The following is a description of a gene set: from publication Cui A, Huang T, Li S, Ma A, Pérez JL, Sander C, Keskin DB, Wu CJ, Fraenkel E, Hacohen N (PMID 38057668) Genes positively differentially expressed in cell type: Macrophage upon treatment with cytokine: IFN-γ in mouse lymph nodes in vivo. Cytokines mediate cell-cell communication in the immune system and represent important therapeutic targets. A myriad of studies have highlighted their central role in immune function, yet we lack a global view of the cellular responses of each immune cell type to each cytokine. To address this gap, the authors created the Immune Dictionary, a compendium of single-cell transcriptomic profiles of more than 17 immune cell types in response to each of 86 cytokines (>1,400 cytokine-cell type combinations) in mouse lymph nodes in vivo. A cytokine-centric view of the dictionary revealed that most cytokines induce highly cell-type-specific responses. For example, the inflammatory cytokine interleukin-1β induces distinct gene programmes in almost every cell type. A cell-type-centric view of the dictionary identified more than 66 cytokine-driven cellular polarization states across immune cell types, including previously uncharacterized states such as an interleukin-18-induced polyfunctional natural killer cell state. Mouse Gene Set: CUI_MACROPHAGE_IFNG_RESPONSE_UP species: Mus musculus, and this is the list of marker genes: Oasl2, Abhd17b, Plaat3, Arf6, Socs1, Gatm, Ube2l6, Socs2, Eif1a, Glipr2 (NCBI Gene Id 97132, GLI pathogenesis-related 2), Fcgr1, Prkx, Ccl8, Btg1, Pphln1, Parp12, Usp18, Themis2, Stat3, Rmdn3, Slamf8, Crem (cAMP responsive element modulator), Sell, Actg1, Vdac2 (voltage-dependent anion channel 2), Sumo2, Gnaq, Cycs, Basp1, Psme2, Vwf, Ifitm1 (interferon induced transmembrane protein 1), Irf7, Rtp4, Flot1, Irgm2, H3f3b, Ccl7 (NCBI Gene Id 20306), Mndal, Spi1, Gpt2, Parp9, Eef1e1, Casp8, Ilrun, Ifit2 (interferon-induced protein with tetratricopeptide repeats 2, NCBI Gene Id 15958), Irgm1, Ube2d3, Iigp1, Etf1, Psmb9, Pmpcb, Nampt, Hprt1, H2-T23, Sp110, Gbp4 (NCBI Gene Id 17472), Jund, Pfkp, Gbp8, Fam241a, Zbp1 (Z-DNA binding protein 1), Lcp2, Batf3, Gabarap, Eif4a1, Fcgr3, Il1a, Cxcl9, Mkrn1, Ly86, Cdkn1a, Litaf, Gch1, Sdcbp, Fcgr4, Batf2, Casp4, Psme1, Scimp, Psmb10, Plek, Tnfaip2, Casp1, Stat5b, Gbp3 (NCBI Gene Id 99898), Rnf19b, Cfl1, Cxcl10, Fbxl5, Rufy3, Igtp, Snap23, Creb3, Ppa1, Irf1, Eif5a (NCBI Gene Id 28059), Max, Ccdc25 (NCBI Gene Id 67179), Clec4n, Cnn3, Tma16, Gbp2, Bmp2k, Samhd1, Sp100, Pnp, Lrrc59, Atp5mk, Lap3, Slc15a3, Gimap5, Ifi204, Arpc2, Tpm4, Sting1, Isg15, Trim30a, Procr, Klf6, Cebpd, Stx7, Prr13, Ifi205, Hk3, Zfand6, Ank2, Ifi213, Stx11, Phf11d, Wars1, Clic4, Pdcd6ip, Arid5a, Tle1, Arf4, Trafd1, Ccl12 (NCBI Gene Id 20293), Agfg1, Atad1 (ATPase family, AAA domain containing 1), Gbp2b, Odc1, Gbp5, Stat1, Cebpb, Cd40, Vim, Txndc17, Slfn5, Tspo, Psma3, Serpina3g, Jpt1, Rap2c, Irf8, Homer1, Ifi206, Spop, Serpina3f (serine (or cysteine) peptidase inhibitor, clade A, member 3F), Cdc42ep2, Osgin1, Cmpk1 (NCBI Gene Id 66588), Cd274, Gbp7, Hnrnph2, Pfn1, Calhm6, Slc31a1, Anxa7, Snx10, Atp6v1b2, Dtx3l, Arpc5, Ccdc71l, Ptpn1, Rbms1, Ccl2, Pim1, Serpinb9, Ifitm3, Mcub, Ifi211, Ranbp1, Gng11, Hilpda, Ubd, Txn1, Ifi203, Zyx, Ifi47, Clec10a, Mlkl, Pi4k2a, Dok2, Stat2, Ogfr, Ifih1, Cacybp, Cited2, Sod2